The following is a description of a gene set: Human Gene Set: MORF_CTBP1 Neighborhood of CTBP1 studied in species Homo sapiens Neighborhood of CTBP1 C-terminal binding protein 1 in the MORF expression compendium, and this is the list of marker genes: LYPLA2, CAPZB, MARK3, EIF3K, XRCC5, NRDC, SET, NACA, SUMO3, ANAPC5, COX7C, EFCAB14, HADHA, ZNF384, DDX49, UQCRB, PARK7, PPP1R7, FAM120A, TRAPPC3, CHD4, NDUFS3, SRSF9, CLTA, ARPC2, AP3S1, HMGN1, PPP2R1A, PPP1CA, MRPS12, DAZAP2, MRPL9, COPS6, IST1, DAP3, LYPLA1 (lysophospholipase 1), DNAJC8, HNRNPAB, GPAA1, PSMB1, FBXO9, EIF3H, ANP32B, YWHAQ, NARS1, XPO1, NCL, DEK, CCT7, ACAA1, RPN1, UBE2I, HNRNPUL1, GANAB, EIF4H, SEPTIN2, DICER1, AP2M1, SLC25A3, YWHAB, NDUFV1, U2AF1, MBD4, TADA3, HDAC1, SYPL1, SUMO1, SETD3, GAK, MAEA, PTBP1, GPN1, YWHAZ, SSR2, NDUFA2, CALM2, CTBP1, IDH3B, SNRNP70, DRG1, KHDRBS1, GMFB, VPS52, CCT2, PGK1, RHEB (Ras homolog, mTORC1 binding), GATD3, XRCC6, GDI2, CAP1 (NCBI Gene Id 10487), RAN (NCBI Gene Id 87046), CNBP, STARD7, ACLY, PCBP2, BTF3, VDAC2, COX6B1, ARFGAP2, XPO7, SNRPE, EIF1AX (NCBI Gene Id 83754), GNB1, DYNLL1, SRP14, HNRNPC, NONO, RAD23A, IMPDH1, AP3D1, FNTA, JTB, NDUFS4, TIAL1, HADHB, EIF4G2, PSMA4, CYC1, SNX3, CANX (calnexin), UBE2L3, MGRN1, H2AZ2, COX4I1, ADD1, POLR2I, MDH1 (malate dehydrogenase 1), AP1B1, DHX38, KXD1, UQCRFS1, UBA1, CSK, CBX3 (chromobox 3), RHOA (ras homolog family member A), TMED2, PSMB7, BAG6, PCMT1, DIAPH1, SF3B2, HSP90AA1, HNRNPD, WDR1, CAPZA1, SNRNP200, FAM168B, ACP1, CSNK2B (casein kinase 2 beta), GNB2, PUF60, MRPL23, PIEZO1, DDX39B, RNPS1, HNRNPK, SUMO2, COPS5, TARDBP, UBA2, MTDH, SRP9, PIN1, CTDNEP1, ARHGAP1, KARS1 (NCBI Gene Id 3735), COX5B, HDGF